The following is a description of a gene set: Human Gene Set: GSE18791_UNSTIM_VS_NEWCATSLE_VIRUS_DC_18H_DN species: Homo sapiens from publication Zaslavsky E, Hershberg U, Seto J, Pham AM, Marquez S, Duke JL, Wetmur JG, Tenoever BR, Sealfon SC, Kleinstein SH (PMID 20164420) The dendritic cell (DC) is a master regulator of immune responses. Pathogenic viruses subvert normal immune function in DCs through the expression of immune antagonists. Understanding how these antagonists interact with the host immune system requires knowledge of the underlying genetic regulatory network that operates during an uninhibited antiviral response. In order to isolate and identify this network, we studied DCs infected with Newcastle Disease Virus (NDV), which is able to stimulate innate immunity and DC maturation through activation of RIG-I signaling, but lacks the ability to evade the human interferon response. To analyze this experimental model, we developed a new approach integrating genome-wide expression kinetics and time-dependent promoter analysis. We found that the genetic program underlying the antiviral cell state transition during the first 18-hours post-infection could be explained by a single regulatory network. Gene expression changes were driven by a step-wise multi-factor cascading control mechanism, where the specific transcription factors controlling expression changed over time. Within this network, most individual genes are regulated by multiple factors, indicating robustness against virus-encoded immune evasion genes. In addition to effectively recapitulating current biological knowledge, we predicted, and validated experimentally, antiviral roles for several novel transcription factors. More generally, our results show how a genetic program can be temporally controlled through a single regulatory network to achieve the large-scale genetic reprogramming characteristic of cell state transitions. Genes down-regulated in comparison of control conventional dendritic cells (cDC) at 18 h versus cDCs infected with Newcastle disease virus (NDV) at 18 h., and this is the list of marker genes: RIPOR2, INAFM1, CHMP5, DDX60, SAT1, HELZ2, H4C9, RIPK2, TMEM54, GPBP1, TTF2, PPM1K, CCL5, HSPA1L, FEV, INTS12, CCDC191, CD38, GBP5, LRP2, SAMD9L, CLDN5, SMG1P1, MAGEA11, KRT79, LINC01003, PPP1R3E, HAPLN3, TMPO-AS1, DDX60L, NFKBIZ, RSAD2, LINC00895, OASL, ATP10A, EZH2, LYSMD2, FRS3, AZIN2, SLC6A1, IRF7, CEACAM5, XAF1, LRRN4CL, USP42, TMEM190, LINC01304, CXCL10, TMEM268, KLK11, TMEM217, ADRA2C, MRPL40, TAF5LP1, MIR1-1HG, VIT, SYNPO2 (NCBI Gene Id 171024), GLCCI1, KRT25, CYMP, TRAFD1, ARHGAP27, HRCT1, CACNA1A, OAS1, PHF11, MX2, APOA1 (NCBI Gene Id 335), CT75, TRHDE-AS1, C5orf46, TRIM22, MKX (mohawk homeobox), SYNE3, MAP3K8, TJP2, OTUD1, HERC6, FAM81B, PASD1, SHFL, FBXO7, S100G, ZBP1, ZNF445, WTAP, NSUN7, PDE4B, MASTL, IRAK2, PARP14, LINC00851, IFIT1, SAMD9, CARINH, TP73, ILF3-DT, BTN1A1 (butyrophilin subfamily 1 member A1), TBXT, TRAF6, NBN, PMAIP1, DNALI1, SECTM1, CFAP210, HCG4B, CD274, HOXB8, GBP1, IFI44L, IER2, HERC5, PTGS2, CSPG4BP, CSRNP1, AIM2, RPS6KC1, CCL8 (NCBI Gene Id 96488), KLKB1, TRNT1, MPV17L, IL15, CALHM6, OAS3, B3GNT8, TNFSF10, FOSL1, NT5C3A, RICTOR, IFIT2, NEDD1, BATF2, DOCK8-AS1, BCL2, DHX58, SELENOO, CRYBB2P1, ACACB (NCBI Gene Id 32), GMPR (guanosine monophosphate reductase), SLC15A2, SLAMF7, MYD88, LINC01016, GBP2, TNFAIP6, EPSTI1, TAP2, B4GALT5, STON1, COQ10B, DSPP, UBQLNL, ALK, MX1, PATE2, IFIT5 (interferon induced protein with tetratricopeptide repeats 5), MIR155HG, FXYD1, PI4K2B, NUP58, OLIG1, RETNLB, EFEMP2, CSRP2, TFEC, CMPK2, IFI44, IFIH1, IRF1, PELI1, ZNF214, C21orf91, PLSCR1, NEURL3, EFHB, ANKRD34A, ATP12A (NCBI Gene Id 479), RIGI, PLA1A, ERBB4, TRIM26, PRCD, NCOA7, LINC01138, CNP, MAP3K15, MIR9-1HG, PNPT1, ZSCAN12, GADD45B, PLD4, STAT1